The following is a description of a gene set: Human Gene Set: GOMF_LIGASE_ACTIVITY_FORMING_PHOSPHORIC_ESTER_BONDS species: Homo sapiens Catalysis of the joining of two molecules, or two groups within a single molecule, via a phosphoric ester bond, with the concomitant hydrolysis of the diphosphate bond in ATP or a similar triphosphate., and this is the list of marker genes: RTCB, AARS2, LIG4, AARS1, RLIG1, LIG1, RTCA, LIG3